Given this list of marker genes AKT2, ITGBL1, MMP13, AKT1, RUNX2, CBFB, ITGA5, AKT3, here is a description of the gene set: Human Gene Set: REACTOME_RUNX2_REGULATES_GENES_INVOLVED_IN_CELL_MIGRATION RUNX2 regulates genes involved in cell migration studied in species Homo sapiens